The following is a description of a gene set: studied in species Homo sapiens Human Gene Set: GOBP_EMBRYONIC_CAMERA_TYPE_EYE_DEVELOPMENT The process occurring during the embryonic phase whose specific outcome is the progression of the eye over time, from its formation to the mature structure., and this is the list of marker genes: PAX2, TWIST1, SP3, FOXF2, WNT16, ALDH1A2, HIPK2, CITED2, TRAF3IP1, BMP7, WDR19, STRA6, IFT140, FRS2, KDM2B, TULP3, PHACTR4, ALDH1A3, RARG, PITX2, SIX3, TH, TFAP2A, ZEB1, TBX2, IHH, HIPK1 (NCBI Gene Id 23323), FGF10, CRYAA, RDH10, IFT172, PROX1, WNT5A, CDK20, PPP1R13L, FZD5, PAX6, RARA, NES, SOX11